Given this list of marker genes MYL11, NOG, SCN1A, GABRG2, PCDH19, SCN9A, GDF6, SCN1B, MEOX1, GABRA1, SCN2A, here is a description of the gene set: Limited neck range of motion species: Homo sapiens Human Gene Set: HP_LIMITED_NECK_RANGE_OF_MOTION